The following is a description of a gene set: A process that is carried out at the cellular level which results in the assembly, arrangement of constituent parts, or disassembly of the microtubule spindle during a mitotic cell cycle. Mouse Gene Set: GOBP_MITOTIC_SPINDLE_ORGANIZATION studied in species Mus musculus, and this is the list of marker genes: Hnrnpu, Lsm14a, Cltc, Stil, Eml3, Pibf1, Chek2, Cep192, Ints13, Smc3, Birc5, Clasp2 (CLIP associating protein 2), Ccdc61, Sbds, Misp, Arhgef10, Hspa1a, Bora, Rae1, Dctn1, Ccnb1-ps, Tpx2, Kif23, Cdca8, Prickle1, Aurkc, Smc1a, Spc25, Nuf2, Abraxas1, Cdc20, Golga2, Dync1h1, Khdc3, Chmp4b, Nup62, Tpr, Kifc5b, Kif15, Cenpj, Efhc1, Rcc1 (regulator of chromosome condensation 1), Map1s, Pkd1, Psrc1, Rhoa, Spice1, Kif11, Stag2, Uhrf1, Poc1a, Incenp, Eml1, Ccsap, Map9, Dctn6, Racgap1, Ndc80, Chmp4c, Chmp2a, Chmp7, Ofd1, Chmp1b2 (charged multivesicular body protein 1B2), Nudc, Cenpe, Chmp3, Map10, Vcp, Kif2a, Pcnt, Tacc1, Stag1, Mybl2, Map4, Ilk, Tacc2, Bccip, Dlgap5, Ripor2, Chmp1b, Aurkb, Ccnb1, Sass6, Tacc3, Aaas, Chmp5, Drg1, Plk1, Chmp6, Plk5, Prc1, Dctn2, Ccdc66, Gnai1, Aurka, Kif3b, Tbce, Tubg1, Rangrf, Zfp207, Stmn1, Afg2b, Abraxas2, Wdr62 (NCBI Gene Id 76446), Rab11a, Clasp1, Hspa1b, Plk3, Fsd1, Snhg15, Spast, Nek2, Mzt1, Ptpa, Kpnb1, Vps4b, Wrap73, Chmp1a, Flna, Cep126, Numa1, Fam110a, Plk2, Kif4, Chmp2b, Tubg2, Cenph, Ankrd53 (NCBI Gene Id 75305), Poldip2, Parp3, Kifc1, Ckap5, Gpsm2 (NCBI Gene Id 76123), Cep97